Given this list of marker genes PHYHIPL, CAPRIN1, PPP2R5E, ZBTB20, AHNAK, G6PC2, ZHX1-C8orf76, ZNF217, DEPDC1B, NWD2, NUTF2, AUNIP, ANKRD44, GPR83, CFL2, WFDC8, CNR1, CAPN6 (NCBI Gene Id 827), ROCK2, TSPAN14, NR2E3, ARL6IP1, PCGF5, LRP2, PAK4, TMEM62, FSD2, SLC12A6, RAP2A, EDEM1, SCD, SPINK8, TNFRSF19, SESN3, TNFSF10, ECM2, ADAMTS3, APOH, TAB2, SERPINE2, RALGPS2, FBXL20, ALX4, NRG1 (NCBI Gene Id 653104), UPRT, SH3GLB1, NDUFB6, FRY (NCBI Gene Id 404759), RILPL1, ABLIM3, PDS5A, PNRC1, C9orf40, TRA2B, ITPK1, SLC7A1, EVI5, PPM1K, PCDH7, AK3, LPAR4, AKAP9, FGF2, UNC80, G3BP2, PON2, TRIP11, PAWR, GUCY1A2 (guanylate cyclase 1 soluble subunit alpha 2), KDM6A, ATP6V1C2 (ATPase H+ transporting V1 subunit C2), COL12A1, PIGA, CCDC88A, DNHD1, FANCD2, NACC2 (NCBI Gene Id 138151), KATNBL1 (katanin regulatory subunit B1 like 1), ARL6IP6 (NCBI Gene Id 151188), NECTIN2, DDIT4, STRIP2, RFX3, SLC7A13, ORMDL1, SLC39A10, ATAD1, ERI1, TMEM170A (NCBI Gene Id 124491), RB1, MTHFD2, SCAF11, SLC24A2, TRAF3IP1, GCNT1, PTPN3, LLGL2, TAOK1, EPHA5, PRKX, SETD2, TRIM72, GNA12 (NCBI Gene Id 654140), ATP5MC3, FDX1, ITGA6, STAU1, TPPP, SINHCAF, CELSR2, RPAP3, ALDH3A2, WNK1, EFHD2, NCOA1, PDE4B, RIGI, ZBTB43, SDC2, SESTD1, MBD4, C17orf100, CYP19A1, USP37, ZNF347, ARSB, CHSY3 (NCBI Gene Id 337876), SLC4A7, SGPP2, RUNX1, ZNF99, CEP85L, HS3ST5, PLPP3, ISY1, SEC62, API5, GTF2A1, PCDH17, CCDC85C, HSPA5, MAPKAPK2, RNGTT, ITGA3, OTUD6B, EP300, NUFIP2, UQCRB, FXR1, TRIM2, GNPTAB, BCLAF1, ZBTB4, SEC16B, RABEP1, GALNT7, PTER, HS2ST1, HSF5 (heat shock transcription factor 5), ADAMTSL3, UBE2J1, DNAAF5, PSG1, ANKRD46, FGF7, CD2AP, CUL2, LIN28B, KLHL3, GIMAP2, PPP2R2A, KNCN, SEPTIN2, RALGAPA2, CALD1 (NCBI Gene Id 800), ANKRD17, BCAR3, LYRM2, NLK, SEMA3A, EMC1, GOLIM4, MAP3K5, CREBBP, GPR137C, LRRTM2, here is a description of the gene set: Genes predicted to be targets of miRBase v22 microRNA hsa-miR-222-5p in miRDB v6.0 with MirTarget v4 prediction scores > 80 (high confidence targets). Human Gene Set: MIR222_5P from publication Chen Y, Wang X (PMID 31504780) studied in species Homo sapiens